Given this list of marker genes Ndufab1-ps, Ciao2b, Ciao1, Ciapin1, Glrx3, Ciao2a, Bola3, Nubp1, Nfu1, AK157302, Ndor1, Nubpl, Abcb7, Bola2, Nfs1, Iscu, Isca2, Glrx5, Hscb, Fdx2 (NCBI Gene Id 68165), Nubp2, Ciao3, Iba57, Isca1, Ndufab1, Hspa9, Fxn (NCBI Gene Id 14297), Xdh, Lyrm4, here is a description of the gene set: Mouse Gene Set: GOBP_METALLO_SULFUR_CLUSTER_ASSEMBLY The incorporation of a metal and exogenous sulfur into a metallo-sulfur cluster. species: Mus musculus